The following is a description of a gene set: Mouse Gene Set: GOBP_VASCULATURE_DEVELOPMENT The process whose specific outcome is the progression of the vasculature over time, from its formation to the mature structure. The vasculature is an interconnected tubular multi-tissue structure that contains fluid that is actively transported around the organism. studied in species Mus musculus, and this is the list of marker genes: Wnt7b, Sparc, Serpinf2, Robo1, Tnn, Large1, Anxa3, Tafa5, Sgpl1 (sphingosine phosphate lyase 1), Zc3h12a, Gbx2, Tcf4, Pgk1, Setd2, Syk, Ncoa6, Ramp1, Cysltr1, Nog (NCBI Gene Id 18121), Hmgb1, Hdac7, Mylk, Mapk14, Kit, Ric8a, Mcam, Col4a2, Cemip2, Wt1, Hhipl1, Sp100, Wars2, Tiparp, Nfe2, Creb3l1, Pparg, Slc2a10, Hoxa3, Cma1, Notch1, Pkd2, Abcc9, Fgf8, Pdgfd, Cav1, Cntrl, Kif7, Lrp1, Bmp7, Ptn, Naa15, Itgb2l, Mexis, Nr4a1, Grn, Stard13, Col1a2, Bcam, Ppp3r1, Serpine1, Pknox1, Micall1, Minar2, Adtrp, Pbrm1, Add1, Bax (NCBI Gene Id 12028), Hif3a, Cdx4, Dync2h1, Luzp1, Tgfbr2, Clic4, Ptk2, Osr1, Tbx1, Ereg, Psen1, Smarca4, Pik3r2, Bmpr2, Prrx2, Thbs1, Camp, Meis1 (Meis homeobox 1), Ephb3, Fkbpl (FK506 binding protein-like), Cdh13, Sash1, Foxn1, Sirt1, Shb, Efemp2, Foxs1, Pdgfrb, Gper1, Ahr, Cited1, Heg1, Egln1, Vav3, Trex1, Angptl4 (NCBI Gene Id 57875), Esm1, Myocd, Hif1a, Epgn, Hbegf, Gpr15, Bak1, Gja1, Comp, Cldn5, Hoxb3, Cybb, Ccl24, Hoxa13, Slc39a12, Rspo3, Map3k3, Ctsh, Fzd4, Rock2, Gata4, Hipk2, Vav2, T, Itgb1bp1, Hs6st1, Adgrf4 (adhesion G protein-coupled receptor F4), Xbp1, Gm28729, Brca1, Hgf, Pax6, Slc31a1, Fuz, Etv2, Dctn5, Apold1, Alox5, Itga5, Hc, Cyp1b1, Chrd, Adam8, Jmjd8, Hdac5, Tspan12, Anpep, Plau, Nprl3, Adm2, Wnt4, Flna, Glul, Cdh5, Notch2, Mir23a, Parva, Ifng, Adamts9, C1galt1 (core 1 synthase, glycoprotein-N-acetylgalactosamine 3-beta-galactosyltransferase, 1), Smarca2, Pkd1, Tnfaip2, Cxcr2, Amot, Aggf1 (angiogenic factor with G patch and FHA domains 1), Itgb1, Cxcr3, Erap1, Flt4, Hspb1, Rap1a, Casp8, Gaa, Dnmt1, Rela, Socs3 (NCBI Gene Id 12702), Ddah1, Pten, Plg, Akt3 (NCBI Gene Id 98462), Rxra, Vps4b, Spint1, Sos1, Col1a1, Acvr2b, Gjc1, Hectd1, Nus1, Wnt2, Foxc2, Spry2, Pxn, Kctd10, Prkd2, Cripto, Adipor2, Gab1, Ptgis, Tmem201, Mapk1, Sox4, Cysltr2, Rhoa, Ccl11, Sfrp2, Nox1, Meox2, Crhr2, Gna13, Tmed2, Wnt7a, Zbtb14, Abcc8, Fgf6, Ccr2, E2f2, Aplnr, Gpc3, Ndnf, Kdr, Ang5, Shh, Flvcr1, Fgfbp1, Il1b, Antxr1, Fgf1, Smad6, Pik3c2a, Tgfbr1, Fap, Gdf2 (growth differentiation factor 2), Snx17, Srpx2, Fosl1, Hhip, Tnni3, Mir126b, Stat3, Htatip2, Errfi1, Smad7, Nrcam, Fam3d, C5ar1, Rapgef2, Grem1, Robo4, Map2k5, Foxc1, Angpt4, Arhgap24, Ptprj, Lyl1, Fmnl3, Tead2, Cdx2, Stk4, Ephb4, Anp32b, Cd59a, B9d1, Pik3cd, Hmga2 (NCBI Gene Id 77357), Itgb3 (integrin beta 3), Foxo1, Nsdhl, Hhex, Tfap2b, Adam10, Uts2, Adrb2, Cspg4, Pcsk5, Yap1, Mtdh, Ngfr, Thy1, Fgf10 (NCBI Gene Id 14165), Vegfd, Igf2, Zmiz1, Ppp1r15a, Emc10, Plcd3, Folr1, Hrg, Adam12, Hpgd, Sema4a, Tnfsf12, Unc5b, C3, Esx1, Ctnnb1, Myo18b, Atp5f1b, Ecscr, Hmox1 (NCBI Gene Id 27970), Lif, Foxj2, Brpf1, Jmjd6, Foxm1 (NCBI Gene Id 98186), Elk3, Egr2, Acvrl1, Sec24b, Acta2, Ntrk2, Bcas3, Arid1a, Slit2, Mir145a, Prok2, Ubp1, Tgfb1, Jam3, Fbxw8, S2bpcox16, Rom1, Mir24-1, Sema6a, Cxcl12, Klf4, Hey2, Stat1, Isl1, Flt1, Adgrb1, Plcd1, Atp2b4, Itgax, Ccl5, Ramp2, Nr2e1, Gtf2i, Pik3cb, Il12b, Cxcl17, Tbxa2r, Bsg, Plpp3, Immp2l, Serpinf1, Hdac9, Sema5a, Med1, Map2k1, Acvr1, Tmem231, Arid2, Rhob, Jup, Tbx20, Lgals3, Jcad, Pdcd4, Ghsr, Pkm (NCBI Gene Id 18746), Thsd7a, Robo2, Stab1, Col5a1, Rbpj, Tnfrsf1a, Ccr3, Rtl1, Ggnbp2 (NCBI Gene Id 97681), Pcdha9 (NCBI Gene Id 192161), Edn1, Plxnd1, Megf8, Dcn, Stra6, Npr2 (natriuretic peptide receptor 2), Wnt5a, Epha2, Fbln5, Vangl2, Apoe, Il6ra, Aldh1a2, Pdpn, S1pr1, Tab1, Sox18, Aimp1, Ltbp1 (latent transforming growth factor beta binding protein 1), Itga2b, Fgfr2, Mrtfb, Itgb8, Pik3ca, Nrp1, Pik3cg, Ago2, Ednra, Lep, Tbx2, Naglu (NCBI Gene Id 27419), Tnf, Smoc2, Egf, Yjefn3, Flvcr2, Mir27b, Cela1, Sulf1, Fbxw7, Epo, Hoxb13, Paxip1, Igf1, Pik3r3, Jun, Mir329, Dysf, B4galt1, Sars1, Ptprm, Tnfsf4, Nfatc3, Cul7, Hspa12b, Lipa, Adgrf5, Epc1, Amotl2, Tnmd, Gata6, Cxcr4, Apela, Ace, Lama1, F3, Nodal (NCBI Gene Id 21792), Ccm2, Tcf7l2, Hand2, Lepr, Prkca, Fkbp10, Tnfrsf12a, Col8a1, Ankrd17, Adra2b (NCBI Gene Id 11552), Adgrg1 (NCBI Gene Id 56037), Fn1, Ppp3cb, Cflar, Wnk1, Tmem100, Rin2, Jag1, Gata2, Ptger4, Pacsin2, Aqp1, Anxa1, Hspb6, Fyn, Cnmd, Rasip1, Egr1, Prl7d1, Cxcl10, Map3k7, C3ar1, Rtn4, Tmem204, Tgfb2, Cd36, Sphk1, Nf1, Ccn1, Mir218-1, Ptgs2, Adgrb3, E2f7, Fgf9, Tie1, Mfge8, Mef2c, Itga7, Enpp1, Ehd4, Ptk7, Hyal1, Ptpn14 (protein tyrosine phosphatase, non-receptor type 14), Lrp2, Egr3, Nrp2, Tgfa (NCBI Gene Id 21802), Angptl3, Lama4 (NCBI Gene Id 16775), Nedd4, Epas1 (endothelial PAS domain protein 1), Ago1, Nos3, Ets1, Agtr1b, Sp1, Epn1, Emp2, Cth, Atp7a (ATPase, copper transporting, alpha polypeptide), Itgav, Sox17, Adm, Fgf2, Rnh1, Mdk, Sgcb, Ccn6, Mia3, Mir27a, Notch4, Tjp1 (NCBI Gene Id 381892), Hpse, Ctnnd1, Ptk2b, Cx3cl1, Prcp, Cd47, Smad1, Col18a1, Pml, Mmrn2, Dnm2, Epor, Fgf18, Cib1, Myo1e, Ang6, Pdgfb, Eya1 (EYA transcriptional coactivator and phosphatase 1), Apob, Llgl2, Dll1 (delta like canonical Notch ligand 1), Angptl7, Efnb2, Vhl, Synb, Sphk2 (sphingosine kinase 2), Gla, Nfatc4, Angpt2, Ihh (NCBI Gene Id 16147, Indian hedgehog), Sod2, Nrarp, Stk11, Ndp, Loxl2, Ptpn20, Ecm1, Mmp2, Emilin1, Adgra2, Uts2r, Ghrl, Pecam1, Pxdn, Edn2, Fasl, Glmn (NCBI Gene Id 170823), Srpk2, Dhcr7, Spi1 (NCBI Gene Id 20375), Tbx3, Crkl, Gpx1, Smo, Mmp21, Cd160, Pofut1, Dicer1, Dlx3, Cfh, H2-M3, Pdcd10, Arhgef15, Gatad2a (NCBI Gene Id 97459), Egfl8, Prkcb, Cfd, Hey1, Il1a, Apln, Il12a, Prdm1, Ceacam1, Vstm4, Slc12a2, Tek, Vash2, Agtr1a, Mecp2, Meis3, Gli3, Ncl, Rgcc, Ntrk1, Ccl2, Nrxn3, Pik3r6, Card10, Ninj1, Dag1, Pdgfra, Fzd5, Angptl6, Prrx1, Spred1, Bmper, Vegfb, Ang2, Tspan18, Epha1, Tmem215, Ptpn6, Plk2 (polo like kinase 2), Col3a1, Btg1, Cdh2, Tbx4, Sh2b3, Xdh, Abl1, Foxo4, Thbs2, Ndst1, Wasf2 (WASP family, member 2), Svep1, Nkx3-1, Vegfc, Ephb1, Ptprb, Zfp36l1, Tlr3, Anxa2, Gadd45a, Vezf1, Zfpm2, Fgfr1, Or10j5, Zfand5, Srf, Actg1, Naxe, Ang4, Tgfbr3, Adamts6, Cd93 (CD93 antigen), Nppb, Six1, Prokr1, Minar1, Ackr3, Il10, Pnpla6, Mmp14 (NCBI Gene Id 17387), Bmpr1a, Nfe2l2, Rapgef1, Optc, Sema3c, Angpt1, Rnf213, Dll4, Myh10, Col4a3, Dsg2, Ngp, Prok1, Zfp354c, Smad5, Col8a2, Pde3b, Ephb2, Itgb2, Rock1, Zfp950, Tgfbi, Reck, Myh9, Adam15, Mmp19 (matrix metallopeptidase 19), Ovol2, Ism1, Ddit3, Il17f, Mir143, Shc1, Otulin, Lgals8, Ccbe1, Akt1, Thbs4, Asb4, Tcf21, Nras, Vash1, E2f8, Ccn3, Prop1, Nfatc2, Pdcd6, Mesp1, Stim1, Cdc42, Ccl12, Wars1, Mdm2, Cd34, Pak4, Id1, Klf2, Gpld1, Mib1, Becn1, Emcn, Cx3cr1, Kat6a, Amotl1, Ywhaz (NCBI Gene Id 68643), Pf4, Ldlr, Mapk7, Plcg1, Nppc, Prkd1, Sgcd, Psg22, Eng, Rras, Rhoj, Atf2, Ppp1r16b, Rora, Chd7, Gja4, Lef1, Junb, Has2, Slc4a7, Vegfa, Egfl7, Comt, Serpinb7, Dab2ip, Cplane1, Chi3l1, Scg2, Sema3e, Mydgf, Pde2a (NCBI Gene Id 207728), Mir218-2, Mmrn1, Cfc1, Lox, Ang, Chm, Rasa1, Pdpk1, Pitx2, Cd40, Epn2, Arhgap22, Krit1, Hspg2, Wdr83, Sirt6 (sirtuin 6), Pank2, Slc1a1 (NCBI Gene Id 319379), Npr3, Efna1, Clec14a, Il18, Hes1, Adamts1, Mir24-2 (microRNA 24-2), Pdcl3, Hoxa1, Prkx, Hgs, Ap2b1, Tgm2, Gpr4, Nkx2-5, Agt, Gja5, Mir23b, Prox1, Cited2, Klf5, Apoh, Tal1, Ift88, Nfatc1, Scn11a, Mmp9, Rapgef3, Bmp4, Col4a1, Kcnj8, Hk2, Adgrb2, Fut1, Emilin2, Clic3, Eif2ak3, Fzd8, Foxf1, Sufu, Notch3, Ccn2, Syde1, Wnt11, Runx1, Nrxn1, Ccdc134, Jak1, Qki, Hand1, Hoxa5, Lemd3, Sec1, S100a1, Lrg1, Lrp5, Enpep (NCBI Gene Id 13809), Prl2c2, Efna3 (ephrin A3), Tert, Calcrl, Foxh1, Pcnt, Pdgfa, Synj2bp, Rbm15, Nr2f2, Pgf, Hoxa7, Bmp2, Prickle1